Given this list of marker genes PSMA7, FBXO5, PSMC3 (proteasome 26S subunit, ATPase 3), UBE2C, CDK1, PSMD7, PSMA6, ANAPC7, PSMB2, PSMD14, PSMC1, PSMC6, ADRM1, PSMA5 (NCBI Gene Id 5686), CCNB1, ANAPC11, CDK2, CUL1, AURKB (aurora kinase B), PSMD1, ANAPC1, PSMB5, ANAPC5, BUB3, AURKA, CCNA1, CDC27, PSMB3, PSMD8, CDC16, SKP2, CDC20, NEK2, UBB, RB1, PSMC2, PSMB6, UBE2D1, CDC26, SKP1, CCNA2, UBE2E1, PSMB1, ANAPC15, PSMB4, ANAPC4, UBC, PSMD3, CDC14A, PSMA1, PSMC5 (proteasome 26S subunit, ATPase 5), PSMA2, ANAPC2, PTTG1, PSMB7, MAD2L1, ANAPC10, BUB1B, UBE2S, FZR1, RPS27A, ANAPC16, PSMD12, PSMA3, PSMD11, SEM1, CDC23, PSMA4, UBA52, PLK1, PSMD6, BTRC, PSMD13, PSMC4, PSMD2, here is a description of the gene set: Reactome Pathway: APC/C-mediated degradation of cell cycle proteins species: Homo sapiens The Anaphase Promoting Complex or Cyclosome (APC/C) functions during mitosis to promote sister chromatid separation and mitotic exit through the degradation of mitotic cyclins and securin. This complex is also active in interphase insuring the appropriate length of the G1 phase. The APC/C contains at least 12 subunits and functions as an ubiquitin-protein ligase (E3) promoting the multiubiquitination of its target proteins (see Gieffers et al., 2001). <br>In the ubiquitination reaction, ubiquitin is activated by the formation of a thioester bond with the (E1) ubiquitin activating enzyme then transferred to a cysteine residue within the ubiquitin conjugating enzyme (E2) and ultimately to a lysine residue within the target protein, with the aid of ubiquitin-protein ligase activity of the APC/C. The ubiquitin chains generated are believed to target proteins for destruction by the 26S proteasome (Reviewed in Peters, 1994 ) <br>The activity of the APC/C is highly periodic during the cell cycle and is controlled by a combination of regulatory events. The APC/C is activated by phosphorylation and the regulated recruitment of activating subunits and is negatively regulated by sequestration by kinetochore-associated checkpoint proteins. The Emi1 protein associates with Cdh1 and Cdc20, inhibiting the APC/C between G1/S and prophase. RSSA1 may play a similar role in ihibiting the APC during early mitosis.<br>Following phosphorylation of the APC/C core subunits by mitotic kinases, the activating subunit, Cdc20 is recruited to the APC/C and is responsible for mitotic activities, including the initiation of sister chromatid separation and the timing of exit from mitosis (See Zachariae and Nasmyth, 1999). Substrates of the Cdc20:APC/C complex, which are recognized by a motif known as the destruction box (D box) include Cyclin A, Nek2, Securin and Cyclin B. Degradation of Securin and Cyclin B does not occur until the mitotic spindle checkpoint has been satisfied (see Castro et al. 2005).<br>Cdc20 is degraded late in mitosis (Reviewed in Owens and Hoyt, 2005). At this time the activating subunit, Cdh1, previously maintained in an inactive phosphorylated state by mitotic kinases, is dephosphorylated and associates with and activates the APC/C. The APC/C:Cdh1 complex recognizes substrates containing a D box, a KEN box or a D box activated (DAD) domain sequence and promotes the ordered degration of mitotic cyclins and other mitotic proteins culminating with its own ubiquitin-conjugating enzyme (E2) subunit UbcH10. This ordered degradation promotes the stability of Cyclin A at the end of G1. This stabilization, in turn, promotes the phosphorylation of Cdh1 and its abrupt dissociation from the APC/C, allowing accumulation of cyclins for the next G1/S transition. <br><br> part of: Regulation of mitotic cell cycle